The following is a description of a gene set: Mouse Gene Set: GOBP_RESPONSE_TO_OXIDATIVE_STRESS Any process that results in a change in state or activity of a cell or an organism (in terms of movement, secretion, enzyme production, gene expression, etc.) as a result of oxidative stress, a state often resulting from exposure to high levels of reactive oxygen species, e.g. superoxide anions, hydrogen peroxide (H2O2), and hydroxyl radicals. studied in species Mus musculus, and this is the list of marker genes: Sirt6, Ppargc1b, Stx2, Ercc6, Ndufs2, Psmb5, Zfp277, Crygd, Ucp2, Ep300 (NCBI Gene Id 328572), Gpr37l1, Cbx8, Arl6ip5, Slc4a1, Rcan2, Plk3, Rnf112, Slc4a11 (solute carrier family 4, sodium bicarbonate transporter-like, member 11), Pycr1, Lonp1, Pex14, Ndufa12, Ndufb4, Stk26, Rela, Nos3, Mt3, Upk3bl, Nox1, Stk24, Sod3, Parp1, Apoa4, Aldh3a2, Scly, Hyal2, Lpo, Gpx4, Ogg1, Net1, Abcc9, Casp6, Ptprk, mt-Nd3, Gja3, Xbp1, Idh1, Crk, mt-Nd5, Ndufb4b, Lrrk2, Fosl1, Ucp1, Col1a1, Kcmf1, Snca (NCBI Gene Id 20617), Coq7, Park7, Pyroxd1, Crygf, Sod2, Rrm2b, Btk, Smpd3, Wnt16, Chrna4, Cst3, Pla2r1, Jak2, Ngb, Atg7, Pex10, Prdx3, Rwdd1 (RWD domain containing 1), Fut8, Sphk1, Oxr1, Dcaf11, Cat, Gjb2, Mutyh, Kcna5, Cd2ap, Romo1, Abcd1 (NCBI Gene Id 11666), Chchd4, Stk25 (serine/threonine kinase 25 (yeast)), Neil1, Nme8, Akt1, Mmp14, Hmox2, Ero1a, Mapk3, Rbpms, Mpo, Msrb3, Aif1, Ngfr, Grk2, Pex13, Hmox1, Cryaa, Hdac6, Kpna4, Txnrd2, Atp7a, Gpx2, Ucp3, Slc11a2, Vkorc1l1, Trpc6, Ddr2, Blvra, Pdgfra, Txnrd1, Pex2 (NCBI Gene Id 52109), Nr4a2, Pycr2, Gstp1, Cryge, Bmp4, Fbln5, Prkaa1, Foxo4, Epas1, mt-Nd1, Ptk2b, Alad, Klf2, Rhob, Plekha1, Mmp9, Sirt1, Rad52, Abcb11, mt-Nd6, Mapk1, Tnfaip3, Scgb1a1, Mtf1, Fyn, Sin3a, Ercc6l2, Cyp11a1, Kdm6b, Slc8a1, Bcl2, Prdx6b (peroxiredoxin 6B), Txn1, Apod, G6pd2, Car3, Ripk1, Cygb, Hgf, Txnip, Map2k4, Epx, Dgkk, Fads2, Ggt1, Pjvk, Ercc8, Tet1, Aldh1a1, Dhrs2, Prkd1, Sp1, Fchsd1, Ppp1r15b, Ern1, Sirpa, Zc3h12a, Pcgf2, Bmal1, Xrcc1, Map1lc3a (NCBI Gene Id 68411), Mapk9, Hspb1, Aaas, Comt, Cryab, Slc25a24, Chchd2-ps, Prdx2, Adcyap1r1, Tor1a, Sesn2 (NCBI Gene Id 230784), Gclm, Prnp, Ppif, Thg1l, Prkra, Rnf146, Nfe2l2, Gsr, G6pdx, Il18rap, Alox5, Capn2, Gpx8, Fkbp1b, Mpv17, Jun, Prr5l, Map3k5, Fer, Lias, Aifm1, Klf4, Rack1, Hao1, Camk2g, Dhfr, Abcc1, Macroh2a1, Ednra, Lck, Tsc1, Prdx1, Ankrd2, Pawr, Etv5, Cdkn2a, Pnpla8, Aqp1, Fxn, Ndufb4c, Fancd2, Foxo3, Ptgs1 (NCBI Gene Id 19224), Rps3, Stau2, mt-Co1, Slc25a14, Pex5, Atf4, Ddias, Selenon, Naprt, Cd38, Atp13a2, Atox1, Pex12, Fgf8, Lncpint, Gata5, Prkn, Ptgs2, Msrb2, Mmp3, Endog, Prkca, Psen1, Pnpt1, Ucn, Axl, Mgst1, Ndufs8, Htra2 (NCBI Gene Id 64704), Il1a (interleukin 1 alpha), Reg3b, Nfkb1, Hyal1, Foxo1, Pdgfd, Aifm2, Prkaa2, Ezh2, Mgat3, Mapk8, Naglu, Mmp2, Lcn2, Pink1, Eif2s1, Chchd2, Tbc1d24, Edn1, Pdgfrb, Apex1, Ccs, Psap, Gpx5, Selenok, Kat2b, Trpm2, App, Mapkap1, Wrn, Epor (NCBI Gene Id 13857), Gpx6, Lig1, Ube3a, Trim25, Nqo1, Stx4a, Rbm11, Slc23a2 (NCBI Gene Id 99086), Becn1, Cdk1, Penk, Pcna, Ggt7, Mctp1, Trpa1, Rlig1, Psip1, Txndc2, Fabp1, Hk3, Rcan1, Egfr, Prdx6, Anxa1, Btg1, Txn2, Ripk3, Cul3, Met, Sod1, Pdcd10, Pdk2, Ppargc1a, Fancc, Tacr1, Sirt2, Coa8, Setx, Adipoq, Pnkp, Tpo, Pxdn, Ermp1, Nme5, Tldc2, Ercc2, Tmigd1, Stox1, Akr1b1, Src, Nfe2l1, Ubr4, Hsf1, Hif1a, Foxa1, Abl1, Chuk, Tat, Slc1a1, Dapk1, Meak7, Hdac2, Ppp2cb, Keap1, Trp53inp1, Capn1, Vrk2, Pld2, Pml, Ercc3, Rgs14, Sesn1, Ankzf1, Banf1, Stat6, Top2b, Mapk7, Casp3, Bak1, Trex1, Slc7a11, Gclc, Col6a1, Gch1, Rbx1, Nudt15, Gpx1, Fos, Arnt, Srxn1, Prkcd, Agap3, Brf2, Mdm2, Selenos, Oxsr1 (oxidative-stress responsive 1), Atp2a2, Stc2, Tmem161a, Ide, Mb, Hnf1a, Cyp1b1, Etfdh, Apoe, Atf2, Ndufa6, Trp53, Nr4a3, Aldh3b1, Gpr37, Usp25, Xpa, Als2, Adam9, Ncoa7, Gpx7, Trap1, Atm, Ppia, Gpx3, Ppef2, Star, Tlr4, Prdx5, Ptprn, Areg, Oser1, Ect2 (NCBI Gene Id 99670), Ambp, Zfp580, 1600014C10Rik, Mapk13, Trim32, Rbx1-ps, Msra, Cfl1, Gab1, Atrn, Il6, Adprs, Bnip3, Cd36, Map2k1, Sdc1, Hspa8 (NCBI Gene Id 69197), Sesn3, Ercc1, Foxp1, Prdx4